Given this list of marker genes Nipsnap2, P2rx7, Stac3, Gpr39, Ednra, Atp2b2, P2rx5, Cracr2a, Bmp4, Ffar1 (NCBI Gene Id 233081), Il13, G6pdx (NCBI Gene Id 14381), Abl1, F2r, Lgals3, Strit1, Sumo1, Clec4b1, Pdpk1, Ppp3cc, Gimap5, Stc1, Ppp3cb, Lilra5, Htt, Stimate, Dbi (diazepam binding inhibitor), Ppp3ca, Jph2 (junctophilin 2), Lpar3, Pdgfrb, Grin1, Ucn, Bak1, P2rx4, Ehd3, Fgf14 (fibroblast growth factor 14), Arrb2, Ccl12, Cxcr3, Vmp1, Capn3, Ank2, Camk2a, Stim2, Ppp3r2, Cask, Atp2a1, Isl1, Hcrt, Asph, Cacnb2, Gsto1, Aplnr, Calm2, Casr, Calm3 (calmodulin 3), Agtr1a, Stim1, Ccr1l1, Trpc3, Creb3, Slc9a1, Plcg2, Cx3cl1, Oga, Trpc6, Calm1, Mchr1, Cldn16, P2rx1, F2rl3, Akap6, Pdgfb, Crh, Adrb1, Bax, Trdn, Trpv3, Stac, Snca, Atp2b1, Drd1, Aqp2, Gjc2 (gap junction protein, gamma 2), Gcg, Thy1, Gstm7, Plp1, Rapgef3, G6pd2, Ntsr1, Ccr1, Cd19, Ccl3, Ccl5, Casq1 (calsequestrin 1), Pkd2, Homer1 (homer scaffolding protein 1), Plcg1, F2, Gimap3, Adrb2, Cxcl9, Cacnb3, Akap5, Gper1, P2ry6, Jak3, Trpv2, Itpr1, Grm6, Mylk, Trpc4, Hap1, Wfs1, Bdkrb1, Wnk3, Dspp, Cxcl10, Npsr1, Cav1, Ppp3r1, Cd4, Cxcr4, Xcl1, Stac2, Orai1, Atp2c2, Hspa2, Sri, Ms4a1, Tspo, Cemip, Cxcl11, Serpine1, Cacna1c, Trpc1, Lhcgr, Cxcl12, Adcyap1r1, Cacna1d, here is a description of the gene set: species: Mus musculus Any process that activates or increases the frequency, rate or extent of the directed movement of calcium ions into, out of or within a cell, or between cells, by means of some agent such as a transporter or pore. Mouse Gene Set: GOBP_POSITIVE_REGULATION_OF_CALCIUM_ION_TRANSPORT